The following is a description of a gene set: Neighborhood of JAK1 Human Gene Set: GNF2_JAK1 studied in species Homo sapiens Neighborhood of JAK1 Janus kinase 1 (a protein tyrosine kinase) in the GNF2 expression compendium, and this is the list of marker genes: RAB29, CTSW, GPR65, NCR3, BTN3A3, STK38, GSAP, CYTIP, ABHD17A, CLEC2B, BIN2, PTPN4, PTPRC, SNRK, CD247, ARHGEF3 (Rho guanine nucleotide exchange factor 3), PLAAT4, RASSF1, FYN, SUN2, STK10, PTGER2, PRKCH, KLRB1, ARL4C, CYTH1, PPP2R5C, ADGRE5, ITGAL, JAK1, RAP1B, HLA-E